The following is a description of a gene set: Any process that results in a change in state or activity of a cell or an organism (in terms of movement, secretion, enzyme production, gene expression, etc.) as a result of a metal ion stimulus. Mouse Gene Set: GOBP_RESPONSE_TO_METAL_ION species: Mus musculus, and this is the list of marker genes: Muc2, Cacna1g, Kcnmb4, Bmp6, Bnip3, Tat, Nek7, Slc13a2, Loxl2, P2rx4, Gpr39, Cybb, Eef2k, Pdx1, Braf, Myog (myogenin), Fosb, Serpina1c, Abcc6, Edn1, Pef1, Mmp9, Trf, Gabrg2, Abat, Abcc9, Gria1, Adgrv1 (NCBI Gene Id 432787), Nlgn1, Ptk2b, Slc12a2, Fech, Ppp2cb, Iqgap1 (IQ motif containing GTPase activating protein 1), Cacng2, Park7, Gpi1, mt-Co1, Mef2c, Gsn, Wnk1, Ahcyl1, Zfp735, Cyp27b1, Slc30a1, Hnrnpd (NCBI Gene Id 330135), Gphn, Mylk, Hfe, Pde1c, Tnnc1, Ncam1, Akt1 (NCBI Gene Id 268604), Crp, Junb, Npc1, Cdk1 (cyclin dependent kinase 1), Snca, Fus, Ggh, Serpinf1, Akr1c18, Kcnj1, Glra3, Atp1a3, Slc39a8, Kcnh1, P2rx5, Hamp, Hvcn1, Ect2, Gsk3a, Grin2a, Adcy1, Rasa4, Itpkc, Chp2, Abcb1a, Jund, Serpina1d (NCBI Gene Id 20703), Hsd17b1, Cpa1, Kcna1, Sucnr1, Anxa11, Zfp616, Htt, Prkaa2, Cpne3, Fbp1, Fga, Mef2a, Sod1, S100a16, Acer1, Tnfrsf11b, Smpd3, Adamts13, Atp7a, Atf1, Abcb6, Cav1, Casp6, Kcnc2, Ryr3, Syt1, Slc25a24, Kcnk3, Alad, Cybrd1, Slc30a3, Hpca, Ass1, Becn1, Pam, Asph, Entpd6, Kmt2a, Pcdh15, Adam9, Jun, Add1, Ucp2, Fgf23, Aanat, Slc30a5, Aldob, Calm2, Carf, Tfap2a, Sec31a, Nfatc1, Gss, Grxcr1, Stk39, Anxa5, Sord, Gabrb3, Mapk1, Rasal1, Mt2, Crhbp, Dlg2, Penk, Serpina1a (NCBI Gene Id 544889), Lct, Kcnmb3, Syt3, Slc13a5, Pln, Tlr9, Dnmt3a, Fxn (NCBI Gene Id 14297), Haao, Kcnb1, Akap5, Kcnip3, Ryr2, Fn1, Map1lc3a, Pkd2, Cpne6, Cpne1, Mdm2, Lta4h, A3galt2, Ddx19a, Tigar, Lck, Fgg, Mt1, Cps1, Gatm, Setd2, Glra2, Eif2s1, Khk, Neurod2, Atp7b, Id2, Trav7-2, Lcat, Atp1a2, Ppif, Calr, Mapk3, Gipr, Rasgrp2, Kcnj10, Mapt, Hsf1, Cdh1, Trpc1, Lcn6, Hamp2, Itpka, Th, Cd14, Cyp1a1, Slfn14, Cpne8, Tfrc, Cebpa, Slc41a1, Kcnmb1, Atp12a, Cuta, Maob, Ptgs2, Trpm2, Pparg, Chuk, Fgb, Smpd1, Thbs1, Anxa7, Kcnc1, Casr, Daxx, Mt3, Cdkn1b, Micu2, Abcc2, Sumo1, Fabp4, Guca1a, Enpp1, Cyp1a2, Lig4, Creb1, Kit, Atp13a2, Pdcd6, Trpv6, Slc25a39, Apobec1, Cp, Nfatc4, Nrxn1, D2hgdh, Zfp658, Sod2, Kcnmb2, Fas, Cyp2a5, Hif1a, Sod3, Trpc3, Uros, Serpina1b, Tnnt2, Ppp5c, Alox5ap, Nqo1, Ireb2, Tcirg1, Cat, Adcy8, Kcnq3, Acta1, Aco1, Xdh, Lrrk2, Cpne9, Tuba1a, Ttn, Bace1, Fos, Inhbb, Nptx1, Foxa2, Endog, Casp3, Cdk4, Lonp1, Itpr3, Cnga3, Slc1a1, Star, Scn5a (NCBI Gene Id 20271), Ryr1, Pgam2, Nudt1, Hcn1, Crip1, Prkaa1, Slc25a12, App, Micu1, mt-Cytb, Slc34a1, Impa2, Calm1, Nfatc2, Atg5, Mt4, Cer1, Hspa8, Hesx1, Slc30a10, Ep300, Calm3, Slc26a5, Dpep1, Adcy7, Tert, Drd2, Bsg, Mttp, Prnp, Slc6a3, Atf4, Txnip, Mapk8, Tfr2, Hnrnpa1, Clic4, Hmox1, Ercc1 (NCBI Gene Id 13870), Mapk9, Pla2g4a, Tspo, Nfe2l1, Gpld1, Lce1d, Plcg2, Otc, Casp9 (caspase 9), Nfatc3, Vps54, Mtf1, Aqp2, Slc11a2, Slc30a8, Ncstn, Egfr, Nfe2l2, Micu3, Shh, Pcna, Abcc8, Capn3, Cyp2r1, Slc30a4, Sox2, Mnat1, Cpne7, Gdi1 (GDP dissociation inhibitor 1), Mcoln1, Dlg4, Plcd1, Ogg1, Gclc, Cldn1, Glra1, B2m, Ppp3ca, Glud1, P2rx7, Wnt5a, Serpina1e, Stim1, Ppp1ca, Camk2b, Slc25a23, Gsk3b, Slc11a1, Itpkb, Kcnma1, Lgmn, Ank3, Cpne4, Krt10, Mecp2, Hmgcs2, Slc25a13, Slc30a2, Kcnq2, Aqp1, Pcsk1, Bcl2, Homer1, Sdc1, Cpne2, Plscr1, Cpne5, Alox15, Il1a